Given this list of marker genes USP8, TP53, ATRX, LCK, FSHR, USP48, BRAF, CDH23, NR3C1, XPNPEP2, here is a description of the gene set: Human Gene Set: HP_ABNORMAL_CAPILLARY_PHYSIOLOGY species: Homo sapiens A functional anomaly of the tiny blood vessels that connect arterioles with venules and whose walls act as semipermeable membranes that mediate the diffusion of fluids and gases between the blood circulation and body tissues. Abnormal capillary physiology